The following is a description of a gene set: Mouse Gene Set: REACTOME_PHENYLALANINE_AND_TYROSINE_METABOLISM Phenylalanine and tyrosine metabolism species: Mus musculus, and this is the list of marker genes: Fah, Tat, Il4i1, Gstz1, Hpd, Asrgl1, Pah, Qdpr, Pcbd1, Kyat1, Hgd